The following is a description of a gene set: species: Mus musculus Mouse Gene Set: GOCC_SYNAPSE The junction between an axon of one neuron and a dendrite of another neuron, a muscle fiber or a glial cell. As the axon approaches the synapse it enlarges into a specialized structure, the presynaptic terminal bouton, which contains mitochondria and synaptic vesicles. At the tip of the terminal bouton is the presynaptic membrane; facing it, and separated from it by a minute cleft (the synaptic cleft) is a specialized area of membrane on the receiving cell, known as the postsynaptic membrane. In response to the arrival of nerve impulses, the presynaptic terminal bouton secretes molecules of neurotransmitters into the synaptic cleft. These diffuse across the cleft and transmit the signal to the postsynaptic membrane., and this is the list of marker genes: Ncstn, Chrm1, Nr1d1, Htr2b, Thbs4, Slc18a3, Rpl35a, Eno2, Cckar, Cnga1, Ror2, Nck2, Syt6 (NCBI Gene Id 99876), Itga5, Gpr37 (NCBI Gene Id 269834), Il1rap, Gjd2, Rab3a, Ppp1cc, Abi3, Rap1a, Neto2, Shh, Eps15, Ano1, Cpne7, Mme, Cbln4, Mylk2, Pde4b, Dscam (NCBI Gene Id 78761), Rab5a, Amph, Slc6a5, Klhl17, Ppp1r1b, Rtn4r, Hnrnpul2, Tagln3 (NCBI Gene Id 80620), Glra4, Gabrg1, Erbb2, Calm1 (calmodulin 1), Fcgr2b, Phactr1, Clcn3, Cpeb2, Rps6-ps4, Htr1d, Rnf220, Cdk5, Syp, Farp1, Hdac4, Crhr2, Sema3a, Shisa9, Cacna1b, Cntnap4, Syt4, Elavl4, Rapgef4, Grn, Pgr, Crmp1, Map1lc3a, Vps35, Ppfia2, Axin1, Myh10, Ppp3r1, Atr, Ank2, Adcy8, Cttnbp2, Kcnn3, Celsr3, Best1, Rpl12, Orai1, Ywhaz, Tprg1l, Rtn3, Chrna5, Sipa1l3, Slc24a2, Eno1 (enolase 1, alpha non-neuron), Dao, Abhd17b, Adora2b, Syt11 (NCBI Gene Id 99745), Elfn2, Septin3, Eef2 (NCBI Gene Id 13629), Bcl2l1, Gapdhrt2, Pacsin1, Th, Nr3c2, Cdh11, Cad, Atm, Amot, Rps10, Svop, Rpl35, Stat3, Psd2, Rtn1, Cabp1, Swap70, P2rx3, Spock1, Cacnb4, Lamc1, Strn (NCBI Gene Id 268980), Kcnj4, Nrp2, Synpo, Cep89, Nwd2, Rab27b, Pias3, Dgkz, Cdh10, Espn, Crhbp, Nufip1, Fchsd2, Srsf10, Mir129-2, Unc5c, Lamp1, Rusc1, Atp1a2, Stim1, Rhob, Dag1, Habp4, Senp6, Faim2, Rps12, Usp5, Neurl1a, Ryk, Nphp4, Gabre (NCBI Gene Id 236851), Clcn2, Caprin1, Cast, Ncam2, F2r, Lck, Map2, Calb1, Ncdn, Rabac1, Ctbp2, Fgf22, Mpp4, Add3, Cln8, Plaa, Pabpc1, Fam81a, Vps18, Wwc1, P2rx6 (NCBI Gene Id 18440), Des, Anxa9, Vhl, Hnrnpf, Cacna1d, Adcyap1, Pcbp1, Baalc, Fgfr1, Tmub1, Pcdh10, Kcnj10, Kcnn2, Ntf5, Stx12, Rgs9, Lgi3, Fxyd6, Plg, Myo5b, Gna13, Ptprd, Lnx1, Neo1, Adora3 (NCBI Gene Id 75846), Nps, Ppfia4, Ano2, Dicer1, Elmod1, Cacng5, Fzd9, Rab13, Akr1a1, Glul, Sez6l, Prkcb, Rab3d, Tpbg, Usp48, Iqsec3, Etv5, Npff, Pfn2, Plekha5, Ap3m1, Nptx1, Osbpl2, Carmil3 (capping protein regulator and myosin 1 linker 3), Abhd17c, Kcna2, Sphk1, Kif17, Mapk8ip2, Clmp, Rab3gap2, Gabrb2, Prkar2b (protein kinase, cAMP dependent regulatory, type II beta), Ap1g2, Sigmar1, Itgb3, Wasl, Pkp4, Psmc4, Atp6v0c, Htr4, C1qc, Vps54, Rap1b, Atp7a, Map2k1, Cadps2, Gng2, Lrfn3, Slc16a1, Hcn4, Slitrk4, Itsn2, Ppm1h, Ptpro, Crtac1, Kctd12b, Apc, Htr3b, Relb, Cblb, Glra2, Nectin3, Stx2, Lrrtm1, Git2, Stx3, Glra1, Mir126a, Rab18, Cngb1, Rgs8, Tppp (tubulin polymerization promoting protein), Ncan, Dab1, Scrn1 (secernin 1), Mtor, Epn1, Cc2d1a, Gabra5, Erbb3, Kif1a, Syt5, Mapk1, Mal2, Chrna10, Vamp4, Gria1, Kirrel3, Slc1a3, Chrnb4, Gnb4, Eif2s2, Stac3, Gpr156, Ap2b1, Rab8a, Ppt1, Dlg5, Hcrt, Rpl8, Sparcl1, Eif4g3, Ghrl, Pik3c3, Vldlr, Hcn3, Ranbp6, Arpc5l (actin related protein 2/3 complex, subunit 5-like), Shisa6, Mir99a, Ddn (NCBI Gene Id 328602), Arf1, Btbd8, Arid1b, Slc1a6, Erc2, Arc, Mical1, Nlgn1, Dennd1a, Als2, Atcay, Jak2, Rpl7, C4b, Cdk5r1, Fcho1, Cacng3, Rps24, P2rx1, Prune2, Kptn, Ncs1, Opn1sw, Rpl27, Rps25, Pcdh8, Rab40b, Stx1b, Trpm7, P2rx2, Rpl23, Actr2, Prkcq, Pmch, Chd4, Picalm, Frmpd4, Itpka, Rph3a, Rps26, Myo9a, C1qa, Adarb1, Htr1a, Lrp4, Samd14, Egr3, Atp6v1e1, Cplx4, Phf24, Itgb1, Mecp2, Frrs1l, Arfgap3, Abl2, Rpl10a, Grin2d, Ache, Slc2a4 (solute carrier family 2 (facilitated glucose transporter), member 4), Ap3b2 (NCBI Gene Id 58995), Ogt, Necab2, Dbnl, Sptan1 (NCBI Gene Id 76356), Cops4, Senp7, Rogdi, Rnf10, Coro1b (NCBI Gene Id 23789), Fxr2, Slc4a10, Dip2a, P2ry1, Ric3, Scamp1, Stau2, Efna2, Tnik, Rmdn3, Drd1, Mapk10, Vti1b, Ext1, Sirt2, Pls3, Drd3, Afdn, Rps3, Lrp8, Capn2, Itsn1, Slc6a4, Cadm2, Inpp4a, Plcb4, Rock1, Tmem163, Eif4a3, Trim9, Chrm2, Kif21b, Fgf12, Nts, Arf6 (ADP-ribosylation factor 6), Cacna1a, Madd, Arhgef2, Kif3a, Lyn, Cntnap1, Eps15l1, Slc18b1, Samd4, Atg7, Cntn5, Gpr179, Dcdc2a, Akap12, Tfrc, Usp46, Akt1, Syt12, Tamalin, Lrp1, Mir153, Ube2l3 (ubiquitin-conjugating enzyme E2L 3), Cd200, Homer1, Rpl31, Htr1b, Slc3a2 (solute carrier family 3 (activators of dibasic and neutral amino acid transport), member 2), Gsk3b, Gnaq, Col4a5, Ppp1r2, Igf1r, Vac14, Rims4, Nbea, Myrip, Cnrip1, Cdc42, Atp6v0a1, Rab11b, Apc2, Nedd4l, Podxl, Gabrq, Rab1a, Rab1b, Prickle2, Eif1ax, Dock4, Napepld, Oprk1, Tmem108, Slc6a11, Gng7, Abhd6, P2ry2, Eif2s1, Ncam1, Mgll, Ptpn5, Bcas1, Dlg4, Dnm1l, Ntng2, Pak3, Ddc, Hnrnpm, Eif3i, Slc6a9, Syt8, Rab40c (NCBI Gene Id 224624), Numb, Disc1, Dapk1, Gria3, Braf, Rap2a, Pfn1, Mir129-1, Slc40a1, Gpc1 (glypican 1), Susd4, Gpr151, Hap1, Pi4k2a, Sharpin, 2510002D24Rik, Magi2, Septin8 (septin 8), Srgap3, Diaph3, Scgn, Pafah1b1, Cnih2, Psd, Kctd8, Sv2a, Syt7, Rps28, Ap1m1, Rab11a, Rps2, Pacsin2, Fcho2, Prrt1, Slitrk5 (SLIT and NTRK-like family, member 5), Htr3a, Lrrc4c (NCBI Gene Id 241568), Lrrtm3, Cck, Gabrb3, Homer3, Strn3, Gap43, Rpl6, Gabbr1, Ilk, Syn1, Rpl24, Rab12, Ptn, Sparc, Elavl1, Gucy1a1, Dbh, Actr3, C4a (NCBI Gene Id 625018), Clcn5, Rps13 (NCBI Gene Id 68052), Pnisr, Sez6, Dock10, Lama2, Tbc1d24, Cpne4, Src, Cdh2, Dst, Eif5, Stxbp1, Sptb, Clstn1, Efnb1, Sumo1, Pip5k1c, Grid2, Eif4g1, Dlgap1, Cbln2, Prkcg, Bdnf, Cacng4, Lingo1, Sh2d5, Anxa5, Shc4, Casr, Sema4d, Syngr3, Fgf7, Kcna3, Cnn3, Ywhag, Phaf1, Eif3d, Hnrnpul1, Sncg, Nr3c1, Slc6a8, Rab6a, Bin1, C1qb, Bsn, Sync, Cdk16, Nckap1, Vcan, Efnb2, Tnr, Rbmx, Kcnip1, Slitrk2, Sptbn2 (NCBI Gene Id 20743), Wdr7, Vdac1, Nectin1, Kcnk9, Rpl32, Dlg1, Atp1a3, Eif6, Rplp2, Calm3, Rpl18, Exoc3, Atp6ap2, Pak2, Ston2, Slc35d3, Sdk1, Mob4, Lrfn5, Nf1, Stx1a, Rpl34, Flna, Gjc1, Nefl, Mir101a, Cntn6, Praf2, Neto1, Hrh4, Pde4a, Atp6v1b2, Cd3e, Nxph4, Eif4a3l1, Syt13, Plxnc1, Pnmt, Nxph1, Gad2, Ttyh1, Ngf, Asic1, Taok2, Gabrr1, Rgs7bp, S1pr5, Rab8b, Grin1, Dclk1, Kif2c, Trpc1, Slc29a4, Kcnj2, Rheb, Prkar2a, Sgip1, Prss12, Npr2, C9orf72, Mt3, Cdh9, Cript, Traf6, Kif5a, Rtn2, Ppp2r2a, Ywhae, Gnb2 (NCBI Gene Id 14693), Snap91, Rab6b, Slc22a3, Chrm5, Limk1, Atp6v0e2, Hnrnpa3, Arhgap22, Aplp2, Kpna2, Nudt3, Mapk3, Prkcd, Aph1a, Npas4, Eif4e, Rab21, Palld, Nlgn4l, Asap1, Pum2, Akap5, Usp8, Synj2, Slc8a1, Plcg1, Ppp2r1b, Rock2 (NCBI Gene Id 77848), L1cam, Ehd1, Camk2n2, Crk, Trpv1, Acp4, Psen2, Cadm4, Cadm3 (cell adhesion molecule 3), Prr7, Ntrk2, Snap47, Nrxn3, Rab10, Syngap1 (synaptic Ras GTPase activating protein 1 homolog (rat)), Clstn3 (calsyntenin 3), Mdm2, Ctnnb1, Mx2, Nedd8, Adora1, Syt1, Npy, Bmpr2, Gnb5, Rasd2, Lzts3, Tmod2, Tpgs1, Arrb2, Cttn, Rps9, Mapk8, Map1a, Rab4a, Enah, Igf2bp1, Rplp0, Psmc5 (protease (prosome, macropain) 26S subunit, ATPase 5), Hip1, Qki, Kif2a, Ly6h, Pten, Gria2, Grik1, Ppp3cc, Ptchd1, Sh3gl1, S1pr4, Nmu, Rps6, Dixdc1, Ube3a, Tacc3, Cadps, Cnnm2, Pdyn, Shisa7, Pura (NCBI Gene Id 70733), Lingo2, Cd47, Rab17, Itgb4, Efna5, Slc8a3, Ap1s1, Rnf216, Hnrnpl, Zdhhc2, Syt17, Rpl30, Syap1, Vps11, Sec22b, Rpl18a, Abi1, Usp9x (NCBI Gene Id 77016), Flot2, Kif21a, Actg1 (actin, gamma, cytoplasmic 1), Adgra1, Ly6g6e, Slc22a1, Snx14, Pvalb, Atg5, Ssh1, Arhgap32, Aak1, Slc6a6, Ap2s1, Rgs17, Esr1, Ralbp1, Eps8, Ppfibp2 (PTPRF interacting protein, binding protein 2 (liprin beta 2)), Rpl9, Cspg5, Sntb2, Rab5c, Rpl10, Syde1, Rpl23a, Elfn1, Pcdh15, Hnrnpd, Eef1d, Gabrb1, Dnajc5, Ap2m1, Rps5, Caly, Sh3gl3, Napg, Cacna2d2, Mpst (mercaptopyruvate sulfurtransferase), Plxna1, Map1b, Fgfr2, Yes1, Wnt5a, Nde1, Mef2c, Gnao1, Lhfpl4, Doc2g, Aldh5a1, Slitrk3, Tor1a, Ncoa2, S1pr3, Capn5, Snx9, Tspoap1, Napb, Mapk9, Rab26, Dnajc6, Ptk2b, Homer2, Gpm6a, Chrna9, Chrm3, Atp1a1, Glrb, Sncb, Sarm1, Rab35, Adra2a, Colq, Sspn, Maf1, Insyn1, Septin1, Rabep1, Kcnd3, Kcnq3, Ston1, Cacng7, Utrn, Atp6v1g2, Cabp4, Eif4ebp2, Grm1, Kcnj3, Slc17a8, Lamb2, Stxbp5, Apba2, Plcb3, Nlgn3, Rims1, Clu, Oprl1, Doc2b, Drp2, Snca (NCBI Gene Id 20617), Adam10, Ntrk3, Chrnb1, Aldh1a1, Zc4h2, Hnrnpdl, Pcsk1, Syngr1, Oprm1, Wipf3, Lrfn4, Eif3b, Tnn, Nsg2, Septin5, Slc16a3, Akap9 (A kinase anchor protein 9), Ctnnd1 (catenin delta 1), Hnrnph1, Pak6, Ptpra, Rpl19, Vcpip1, Parn, Scn1a, Npy1r, Apba3, Pnkd, Cltc, Rps6kb1, Kcnh1, Sema3f, Kifap3 (kinesin-associated protein 3), Wfs1, Hspa8, Ror1, Atp1b2 (ATPase, Na+/K+ transporting, beta 2 polypeptide), Mtmr2, Sv2b, Nrg2, Grin3a, Stx7, Lasp1, Ube2i (ubiquitin-conjugating enzyme E2I), Chmp4b, Epha7, Rps15a, Mapt, Add1, Dmxl2, Grm5, Tsc2, Gabrr3, Dgke, Kcnj6, Aurka, Aqp1, Chrm4 (cholinergic receptor, muscarinic 4), Scamp5, Sorcs3, Itga3, Septin4, Zzef1, Celf6, Hpca, Stx19, Wasf2 (WASP family, member 2), Gabrr2, Tiam1, Scn10a (NCBI Gene Id 208230), Nos1ap, Pias1, Igsf9, Septin7, Cartpt, Synj1, Dok7, Pdzrn3, Snapin, Dcc, Ctbp1 (C-terminal binding protein 1), Sdcbp, Rpl27a, Chrna6, Eef2k, Cplx3, Tsc22d4, Scn9a, Rhoa, Olfm3, Cbln1, Rpl17, Oprd1, Rps15, Cdkl5, Lpar2, Tuba1a, Pde2a, Nt5e (5' nucleotidase, ecto), Arl8b, Mctp1, Cnih3, Sh3glb2, Rps27a, Apbb1, Nrxn1, Rps27, Iqsec1, Fxr1, Atp6v1b1, Eif3a, Kcnd1, Gng12, Egln1, Dpysl5, Tdrd6, Septin11, Rad51, Adgrb1, Nrn1, Agrn, Prima1, Pcdhb16, Stk38, Kcnk1, Lpar1, Slc30a3, Sypl2, Stx6, Ppp3ca, S1pr1, Ablim1 (actin-binding LIM protein 1), Chrnb2, Dock1, Grm2, Mir132, Aldoc, Snx27, Uba52, Slc17a5, Adam22, Sorcs2, Grm8, Ppp1r9b, Tmed9, Snph, Itgb5, Mycbpap, Pclo, Rims3 (regulating synaptic membrane exocytosis 3), Itga8, Cav3, Ckap5, Lrit3, Camk4, Srgap2, Gng13, Fmnl2, Ptprn, Maco1, Dlgap2, Nlgn2, Actn4, Drd2, Rps23, Rgs12 (regulator of G-protein signaling 12), Lrrtm4, Crh, Fgf14, Sos1, Snap29, Fosl1, Syngr2, Rpl11, Baiap2, Nmnat2, Gng3, Nrcam, Ccl2, Ndel1, Trio, Fzd5, Coro1a, Porcn, Rabgef1, Scn2a, Arl8a, Lgi1, Arhgef15, Clta, Pak1, Tulp1, Akap7, Cntn1, Stx4a (syntaxin 4A (placental)), Slc32a1, Shisa8, Elavl2, Snx6 (sorting nexin 6), Mink1 (misshapen-like kinase 1 (zebrafish)), Plcb1, Kcnt1, Fchsd1, Rps7, Ywhaq, Postn, Atad1, Map3k7 (NCBI Gene Id 93774), Hnrnpa0, Rpl21, Kcnma1, Nsg1, Acte1, Acan, Spart, Baiap3, Cep112, Dpysl2, Iqsec2, Btbd9, Abtb3, Gper1, Caskin1, Ap1g1, Fabp5, Eif2b2, Arhgap33, Slc5a7, Macf1, Hnrnpab, Ntm, Nrg3, Ago2, Sh3kbp1, Tanc1, Dlgap4, Fzd4, Gabra2, Emb, Creld1, Tenm2, Igsf9b, Ptprf, Nrp1, Camkv, Eef1a2, Ppfibp1, Olfm2, Npy5r, Stau1, Nckipsd, Elk1, Drd4, Usp14, Hnrnph2, Dstn, Cbln3, Gabrg3, Lats1, Chrna4, Atp2b3, Purg (purine-rich element binding protein G), Trip4, Dnm1, Rps6ka4, Rpl5, Dnajb1, Nr4a1, Syngr4, Rps11, Nog, Slc2a13 (solute carrier family 2 (facilitated glucose transporter), member 13), Lzts1, Aph1c, Nrxn2, Cul3 (cullin 3), Cd24a, Sorbs2, Ablim3, Prph, Daam1, Calm2, Ppp2ca, Atp2b4, Tent2, Dbi, Ntf3, Rps6ka6, Dynll2, Palmd, Icam5, Hnrnpa1, Il31ra, Slc2a1, Grm7, Trpc5, Tac1, Kif3c, Rgs14, Shank1, Kif5c, Actb, Sema4c, Ndfip1, Ntn1, Plxnd1, Atp6ap1, Snx4, Dgkq, Atp6v1a, Mpp2, Cib2, Cyfip2, Kcnq5, Sacm1l, Rapgef3 (NCBI Gene Id 70104), Atp6v1c1, Ptprt, Celf4, Cdh13 (NCBI Gene Id 74373), Rps3a1, Igsf8, Kif3b, Zfp804a, Tnc, Slc38a6, Prkar1a, Shc3, Grin2a, Strn4, Vti1a, Fbxo41, Rpl4, Pnoc, Kcnc4, P2ry4, Rps16, Ina, Cacna1e, Gprin3, Cntnap2, Eif3e, Kpna1 (NCBI Gene Id 16646), Rpl37a, Dact1, Ndufa13, Ank1, Hspb1, Tdrd1, Trim3 (NCBI Gene Id 55992), Chat, Frmpd1, Fbxo45, Kcnc2, Fyn, Chrng, Sri, Zdhhc8, Slc1a7, Git1, Rab2a, Wdr1, Htt, Lama4, Rac1, Dgcr8, Necap1, Syne1, Grik5, Erbin, Nptn, Appl1, Park7, Dpysl3 (NCBI Gene Id 22240), Gna11, Adra1a, Abcc8, Grap, Plxna4, Zdhhc12, Sqstm1, Ube3b, Lamp5, Eif4ebp1 (NCBI Gene Id 13685), Polg, Pcdh17, Slc9a6, Efnb3, Cfl1, Snta1, Abi2, Atp6v1f, Map4, Vwc2l, Tsc1, Vcp (NCBI Gene Id 269523), Dnmbp, Zmynd8, Eif4a3l2, Bace1, Flrt2, Olfm1, Dlg3, Rps6ka1, Prmt8, Slc12a5, Arf4, Atp8a1, Ush1c, Atp2a2, Pianp, Camk2n1, Arl6ip5, Serpine2, Dtnb, Rab33b, Chn2, Abr, Ywhah, Grip2 (NCBI Gene Id 404706), Pdlim5, Rgs10, Cask, Cyth2, Map1s, Sipa1l1, Arrb1, Fus, Erbb4, Psen1, Chrna3, Hapln4, Kcnk2, Synpr, Sema7a, Rtn4, Gnai2, Gucy1b1 (guanylate cyclase 1, soluble, beta 1), Ppa2, Myo5a, Eif5b, Kcna6, Rpl13, Brsk1, Cnr1, Atp6v1d, Tln2, Fgg, Camk2b, Ghrh, Vgf, Rapsn, Gsg1l, Sema4f, Chrna2, Tenm3, Htr2a, Adgrl3, Rpl22, Chrdl1, Vamp2, Ica1, Ntsr1, Sdk2, Wnt3a, Ap2a2, Eea1, Rab11fip5, Mapk14, Rasgrf2, Nrg1, Prkar1b, Wnt7a, Unc13a, Crkl, Clasp2 (CLIP associating protein 2), Camk2g, Hnrnpk, Unc13c (unc-13 homolog C), Napa, Rps4x, P2rx7, Kctd12, Borcs5, Mff, Dvl3, Rasgrp2, Nsmf, Adgrb2, Atp6v1g3, Stk38l, Ninj1, Myo7a, Marcksl1, Rps21, Kcna1, Atp2b1, Dagla, Dpp6, Mark2, Sumo2, Musk, App, Ctnnd2, Gabra1, Plekhg5, Cacna2d1, Rab5b, Ptch1, Slitrk1, Cadm1, Shroom4, Gabra3 (gamma-aminobutyric acid type A receptor subunit alpha 3), Erc1, Sipa1l2, Tmem230, Ptprz1, Dscaml1, Palm, Fkbp1a, Psma3, Prrt2, Fmr1, Cyfip1, Bcan, Rab3gap1, Pde10a, Syt3, Vdac3, Camk1, Pja2, Epha3, Lrrc7, Rnf19a, Cdh15, Grin2c (glutamate receptor, ionotropic, NMDA2C (epsilon 3)), Kcnq2 (NCBI Gene Id 16536), Chrnd, Mark1, 4930544G11Rik, Pin1rt1, Abl1, Mib1, Ephb1, Doc2a, Ngef, Akap1, Chrnb3, Pcbp2, Efr3a, Arhgdia, Cacng2, Hrh3, Mettl5, Nefh, Glra3, Drosha (drosha, ribonuclease type III), Gabarap, Gnb1, Epb41l3, Slc16a7, Grm4, Kcnc3, Pcdha4, Rps19, Nae1, Wasf1, Cpsf2, Slc18a2, Rab7, Gopc, Lrit1, Lypd1, Tufm, Slc6a3, Dmtn, Cryab, Ptprn2, Kcnc1, Cacna1s, Cpeb1, Senp1, Sv2c, Mir125a, Cdh1, Penk, Pak5, Cltb, Ctsd, Abhd17a, Itga7, Ly6e, Dock7, Rps27rt, Prnp, Pdxp, Slc6a17, Rps6kc1, Eif2s3x, Il1rapl1, Rps20, Dnm2, Sh3glb1, Fbxo2, Lrfn1, Arfgap1, Kcnj9, Grin2b, Gapdhrt, Slurp2, Begain, Comt, Stxbp5l, Vps45, Tacr1 (NCBI Gene Id 21336), Syndig1, Slc2a8, Cops5, Ephb2, Grik4, Pdpk1, Rps17, Epb41l1, Vps26b, Adgrl1, Cpeb4, Arpc2, Fubp1, Abi3bp, Ppfia3, Pgrmc2, Myo9b (NCBI Gene Id 17925), Plat, Ngdn (neuroguidin, EIF4E binding protein), Lin7b, Grip1, Sntb1, Mir101b, Tspan7, Dmd, Col13a1, Kctd16, Slc4a8, Ybx1, Slc35f1, Chrna1, Cln3 (CLN3 lysosomal/endosomal transmembrane protein, battenin), Rps18 (ribosomal protein S18), Actn1, Cplx2, Ucn, Rpl28, Sptbn1, Rnf112, Arpc1a, Zdhhc5, Cyp19a1, Mctp2, Dgki, Casp3, Capzb, Grik2, Gria4, Ppfia1, Plcxd3, Anxa7, Wasf3, Hnrnpll, Prickle1 (NCBI Gene Id 68784), Lynx1, Hnrnpr, Atp6v0a4, Syn2, Znrf1, Gdi1, Nptx2, Gnrh1, Prkcz, Ube2m, Gls (glutaminase), Calca, Muc3a, Senp5, Cbarp, Kcnab2, Snx1, Srpx2, Dtna, Zdhhc15, Rph3al, Smcr8 (Smith-Magenis syndrome chromosome region, candidate 8 homolog (human)), Arhgef9, Kcnb1, Arfgef2, Rimbp2, Slc35g2, Ophn1 (NCBI Gene Id 94190), Mdga1, Vdac2, Eif4g2, Egflam, Ghsr, Chrd, Robo2, Stx11, Psmc2, Nedd4, Tnk2, Gpc2 (NCBI Gene Id 71951), Slc18a1, Igsf11, Scrib, Cacng8, Grm3, Slc29a1, Vasp, Slc10a4, C1ql3, Mir221, Lrrtm2, Magee1, Vwc2, Rpl26, Mdga2, Dnm3, Stx16, Pin1, Scn11a, Fzd3, Fam107a, Gripap1, Ube2n, Crhr1, Sypl1, Grin3b, Gnaz, Ptprc, Tiam2 (T cell lymphoma invasion and metastasis 2), Atxn1, Csmd2, Sumo3, Slc1a2, Adam11, Rpl36a, Fgb, Cntn2, Cpt1c, Rpl37, Hip1r, Gphn, Dtnbp1 (dystrobrevin binding protein 1), Rab11fip3, Kcnd2, Arhgap44, Ap1s2, Mir146, Dvl1, Cd2ap, Znrf2 (NCBI Gene Id 68858), Cap1, Unc13b, Trim47, Adgrl2, Rpl15, Syn3, Drd5, Vps33b, Rs1, Igf1, Kalrn, Ap3d1, Myl7, Cpeb3, Cdh23, Whrn, Hras, Grid1, Nppa, Eif3l, Pick1, Got1, Ppp2r1a, Brinp1, Mir143, Pgrmc1, Pld1, Rpl38, Ap3m2, Eif5a, C1ql2, Shank3, Kcna4, Syt9, Lypd6, Cyp46a1, Otof, Entpd1, Bcl11a, Calr, Rab4b, Hnrnpa2b1, Kcnip3, Cdk5r2, Cacna2d3, Cacnb1, Grk2, Cacnb2, Rac3, Lrrc4, Grik3, Hapln2, Zmynd19, Slc17a7, Cnr2, Atg9a, P2rx4, Kif5b, Prkce, Phb2, Asic2, Nrgn, Rims2, Gpsm2, Nptxr, Prkn, Pdlim4, Myh9, S1pr2, Gapdh, Gabbr2, Vps52, Il1rapl2, Igsf21, Hapln1, Snap25, Large1, Dars1, Ppp1ca, Blvrb, Rgs7, Mir134, Slc1a1, Itpr3, Cacna1c, Adrb1, Dlg2, Htr5a, Add2, Actc1, Gpc4, Gabrg2, Apoa4, Rpl13a, Apba1, Fam171b, Syt10, Thy1, Faah, Tmem240, Slc9b2, Ap2a1, Lrrk2, Snap23 (NCBI Gene Id 98773), Vangl2, Prkaca, Phb1, Sst, Flrt3, Srcin1, Mkln1, Itpr1 (NCBI Gene Id 18544), Grk3, Dlgap3, Syde2, Clcn4, Chrna7, Ybx3, Sema4b, Ptpn1, Sorbs1, Met, Ppp3cb, Nefm, Atp6v1h, Rps14, Sort1, Adra2c, Grid2ip, C1ql1, Slc6a1, Tenm4, Epha4, Gnat2, Cap2, Vamp1, Slc8a2, Dgkb, Ush2a, Rela, Rab3c, Myo6, Ntng1, Arhgef7, Kif1b, Cit (NCBI Gene Id 320895), Apoe, Ap3s2, Calb2, Rpl3, Lama5, Tafa4, Gad1, Itga2, Htr7, Slc17a6, Grm6, Canx, Cdh6, Ngfr (NCBI Gene Id 18053), Vps16, Trappc4 (trafficking protein particle complex 4), Slc2a3, Cnksr2, Slc22a2, Rpl29, Slc6a2, Ucn3, Chmp2b, Chrne, Gpr158, Anxa1, Psenen, Kcnj11, Ank3, Usp50, Mlf2, Egfr, Cacna1h, Gabra4, Clstn2, Marcks, Rhog, Wnk1, Lin7c, Clptm1, Elmo1, Cyth1, Camk2d, Tanc2, Spg11, Aph1b, Septin6 (NCBI Gene Id 80615), Eif3f, Prkca, Mapk8ip1, Septin2, Adam23, Actbl2, Prkci, Rab3b, Ptprs, Ppp1r9a, Adgrb3, Cplx1, Fga, Rab14, Mpdz, Pebp1, Ctnna2, Anks1b, Insyn2a, Ly6g6d, Gdi2 (GDP dissociation inhibitor 2), Fbxl20, Gpr50, Kcnj8, Syt2, Ascc1, Bnip3, Bcr, Shank2, Zdhhc17, Prr12, Mir350, Atp6v1g1, Oxt, Gipc1, Atg16l1, Ap1b1, Lrfn2, Flot1, Lin7a, Negr1 (NCBI Gene Id 320840), Ndufs7, Atp6v0d1, Sh3gl2, Rpl7a, Hcn1, Numbl, Adora2a, Anp32e, Sgta, Exoc4, Nipsnap1, Gabrd, Crtc1, Slc30a1, Agap2, Rapgef2, Cpe, Ap3s1, Dcx, Tpd52, Gabra6 (NCBI Gene Id 14399), Vezt, Rplp1, Slc9a5, Rpl14, Rpl36, Mir100, Gng4, Gpc6, Notch1, Rala, Psd3, Plxnb1, Ddx3x, Hapln3, Tubb2b, Dnaja3, C1qbp, Cald1, Eno1b, Nos1, Slc39a3, Cdh8, Diaph1, Arhgap39, Atp2b2, Cxadr, Camk2a, Dbn1, Actn2, Arr3, Adrb2, Scn8a, Slc6a7, Ano6, Adcy1, Filip1, Tdrd5 (NCBI Gene Id 214575), Ptk2, Ezh2, Lrrc4b (leucine rich repeat containing 4B), Plppr4, Rpsa, Vamp3, Iqgap1